Given this list of marker genes SMC3, PLAG1, SRCAP, DPF2, FGD1, KMT2A, CDKN1C (NCBI Gene Id 702), HOXD13, KMT2D, MASP1, BMPR1B, SMARCA4, SOX11, ARID2, TBX5, KDM6A, COL2A1 (collagen type II alpha 1 chain), PUM1, GJA1, WNT5A, SMARCB1, BMP2, SMARCE1, GNAS, SF3B4, GNB2, MEIS2, HNRNPR, RAI1, ROR2, SMARCD1 (NCBI Gene Id 6602), PIK3C2A, PKDCC, COX4I1, DVL1, TBC1D24, IFT140, ZMYM2, RBBP8, ARID1B, WNT7A, ERI1, RUNX2, CUL7, ARID1A, ATP6V1B2, NIN, TBX3, MAPK8IP3, IGF2, RAC1, GDF5, HOXA13, PUF60, ERF, NOG, TFAP2B, CNOT2 (NCBI Gene Id 51498), OBSL1, SMARCC2, EIF4A3, SOX4, KIF15, HMGA2, MYCN, here is a description of the gene set: Aplasia/Hypoplasia of the 5th finger studied in species Homo sapiens A small/hypoplastic or absent/aplastic 5th finger. Human Gene Set: HP_APLASIA_HYPOPLASIA_OF_THE_5TH_FINGER